The following is a description of a gene set: from publication Feuerer M, Hill JA, Kretschmer K, von Boehmer H, Mathis D, Benoist C (PMID 20231436) Human Gene Set: GSE20366_TREG_VS_NAIVE_CD4_TCELL_DEC205_CONVERSION_DN Regulatory T (Treg) cells that express the FoxP3 transcription factor are essential for lymphoid homeostasis and immune tolerance to self. Other non-immunological functions of Treg cells, such as controlling metabolic function in adipose tissue, are also emerging. Treg cells originate primarily in the thymus, but can also be elicited from conventional T cells by in vivo exposure to low-dose antigen or homeostatic expansion, or by activation in the presence of TGFβ in vitro. Treg cells are characterized by a distinct transcriptional signature controlled in part, but not solely, by FoxP3. For a better perspective on transcriptional control in Treg cells, we compared gene expression profiles of a broad panel of Treg cells from various origins or anatomical locations. Treg cells generated by different means form different sub-phenotypes identifiable by particular combinations of transcripts, none of which fully encompass the entire Treg signature. Molecules involved in Treg effector function, chemokine receptors, and the transcription factors that control them are differentially represented in these subphenotypes. Treg cells from the gut proved dissimilar to cells elicited by exposure to TGFβ, but instead they resembled a CD103+Klrg1+ subphenotype preferentially generated in response to lymphopenia. Genes down-regulated in comparison of DEC-Pept Convert versus DEC-Pept CD25- (see Table 1S in the paper for details). studied in species Homo sapiens, and this is the list of marker genes: TMEM9B, FAM83E, SGCD, CNOT11, DUS4L, AP1S2, FASLG, NFATC1, NSD2, SMCO4, GYS1 (NCBI Gene Id 2997, glycogen synthase 1), CHRD, TMEM182, ZNF2, CCDC185, AR, ESM1, P2RY14, ANXA1, ADGRV1, CYP2U1 (cytochrome P450 family 2 subfamily U member 1), HAPLN4, SIDT1, TDRP, ABLIM3, STK38, ADH1C, HSD17B1, DYRK2, HDC, PDZRN3, ARHGAP31, SLC39A9, PRR5L, PNPLA8, NIPA2, HCN1, SLC26A10P, SEMA4A, UBR5, GALM, PDZK1, ATP2B2, ANKRD35, FAM181B, PRDM9, LFNG, IRAK3, HSPB9, SFXN3, KRT7 (keratin 7), IFITM2, ATP7A, ASGR2, CCDC88A, DSP, MOG, PDE7A, MAMDC2, DNAJC6, KCNK16, FAM78A, USP43, RFLNB, FRRS1, CFAP107 (cilia and flagella associated protein 107), RAB33A, ENC1, HOOK3, HAS3, FBXO16, CDKN2C, NEURL1B, SPINK8, SLC9A2, WFIKKN2, HPCAL4, LRRC75B, LYPD6B, KLB, SPICE1, CLDN6, UBE2D3, RYK, KCTD18, ZNF768, AASDH, H2BC18 (H2B clustered histone 18), AP4B1, IL2, CSTF3, TEX15, EOMES, CNTNAP1, CDK20, MINAR2, ZFR, EPB42, IFITM10, ADAMTS15 (ADAM metallopeptidase with thrombospondin type 1 motif 15), TRIP11 (thyroid hormone receptor interactor 11), PHOX2B, GRB14, C11orf65, LEPROT, FANCF, CEP83, AKT3, PSMB11, THEMIS, MFSD6, DAPL1, SLFN12L, P2RX5, SMAD5, TMEM89, ANGPTL2, NAAA, TOX2, TRIM36 (tripartite motif containing 36), ANKHD1, CDH15, CASP1, OPLAH, SESTD1, SLC22A15, SCML4, LANCL3, STMN2, C1GALT1, PHACTR2, TBC1D31, DYSF, SRPK1, IRAK4 (NCBI Gene Id 95458), TCP11, ADAMTS20, SPIN4, ARHGAP29, SMAP1 (small ArfGAP 1), MAN1C1, AP3S1, NCOA6, HNRNPU, REG1A, CAMK2N2, AXIN2, MAF, PLEKHF2, RNF144A, NKPD1, FAM163B, RAD51C, GLDC, ENPP2, NSG2, RARG, RAP1GAP2, ZNF518B, ELOVL7, PBX3, SEMA4F, CEP97, PIGV (phosphatidylinositol glycan anchor biosynthesis class V), RANBP10, RGL1, PMS1, CLDN12, TTLL12, INPP1, ARL10, OTOP3, CFHR1, EGR2, C2orf88, CST11, ASB8, PDE3B, CELA3B, OCIAD2, KHDC1L, PJA1, RAD9B, AMTN, MYH10, ATP8B4, VIPR1, CRYBG3, SH3BP5L, LAMP5, DUSP28, ZNF189, KIT, MTAP, IL7R, CDH2, SYT17, PRSS50, IFNG, CTNNA3